Given this list of marker genes SCG5, WSB2, PCNT, NSDHL, ACAD8, MAGEA1, TIMM17A, ZNF443, NANS, PMEPA1, SHLD2, HMG20A, OMG, SRSF6 (NCBI Gene Id 6431), ZCCHC8 (NCBI Gene Id 55596), SLITRK5, GPM6B, NME8 (NME/NM23 family member 8), ATAD2B, DHX9, CHPT1, ZFP64, NAALADL1, LHFPL2, INPP5F, FNDC3A, ELK3, SGCB, BIN2, MED20, USPL1, TBC1D22B, PDCD1LG2, TRMT5, TUBGCP5, NRN1, ZFAND6, MMP20, THBD, PNISR, ENOX2, C1orf174, NARF, CPSF4, STAG3L4, TBK1, TBCC, MATR3, GNB1, SUGP1, IL1RAPL2, MBTPS1, NAA40, PTPRE, AOC3, SUN1, CTSB, ITGA4, ATP13A3, NGLY1, RAB3GAP2, TRAPPC11, EOLA1 (endothelium and lymphocyte associated ASCH domain 1), OTUB2, PRDX2 (NCBI Gene Id 7001), ARHGAP24, GPRASP1, CDCA3 (NCBI Gene Id 83461), SLC35A1, IFRD1, EPHA2, CCDC47, ANKRD11, APOO, PTBP2, ALDH2, NOP56, HNRNPU, BTD, ZNF692 (zinc finger protein 692), HSPB7 (heat shock protein family B (small) member 7), SEMG1, ZMYM6, STARD7, PAFAH1B1, ENTPD6 (NCBI Gene Id 955, ectonucleoside triphosphate diphosphohydrolase 6), SGF29, TRAPPC13, TSPAN13, RSRP1, TAF11, PLEK2, DNAJC2, PDXDC1, TRMT61B, SND1, SRSF5, CRBN, PCF11, MAN2A2, RO60, TFRC, TMT1A, BTAF1, SLC35E2A, TGFBI, TMEM140, ATG4B, KIZ, UEVLD, JAK2, SLC25A38, TLN2, BTBD3, HDAC9, CBLIF, RNF220 (NCBI Gene Id 55182), PPP4R1, PRPF3, LXN, C5orf22, VOPP1, ODC1, OSBPL9, AGGF1, RSAD1, PTTG1IP, RPS3A, SLC33A1, DUSP5, XPOT, HMGN2, HIP1, ETAA1, YPEL5, ADAM22, NPR2, LIN37, SEC22A, POLB, SLTM, GIN1, PTCD3, N4BP2L2-IT2, IPO5, TMEM164, UPF3B (UPF3B regulator of nonsense mediated mRNA decay), NDST2, SIK1 (salt inducible kinase 1), C2CD5, SMYD2, ZNF223, TAX1BP1, ZNF410, ACACA, SARAF, BOLA1, ANKRD53, SHPK, NOP14, TAF12, UBP1, DLEU2, GPATCH8, HMBS, USP32P2, SNX5, LUC7L3, GLCE (NCBI Gene Id 90998), USP15, DAZAP2, RPL34, GAP43, DYNLT1, DDX5, ARFGEF2, RALB, ETV5, GGNBP2, FAM169A, OTUD4, MED12, DCAF1, PBX3 (PBX homeobox 3), SENP6, POT1, DPP4, LILRB5 (leukocyte immunoglobulin like receptor B5), ARL4A, IPPK, RHCE, ADD1, ALCAM, CLK1, RCN2, CPLANE2, REXO5, PXDN, here is a description of the gene set: Systems vaccinology has emerged as an interdisciplinary field that combines systems wide measurements and network and predictive modeling applied to vaccinology. Here we used the systems vaccinology approach to study the molecular mechanisms underlying th Genes up-regulated in comparison of plasmacytoid dendritic cells from LAIV influenza vaccinee at day 7 post-vaccination vesus those from TIV influenza vaccinee at day 7. Human Gene Set: GSE29618_LAIV_VS_TIV_FLU_VACCINE_DAY7_PDC_UP studied in species Homo sapiens from publication Nakaya HI, Wrammert J, Lee EK, Racioppi L, Marie-Kunze S, Haining WN, Means AR, Kasturi SP, Khan N, Li GM, McCausland M, Kanchan V, Kokko KE, Li S, Elbein R, Mehta AK, Aderem A, Subbarao K, Ahmed R, Pulendran B (PMID 21743478)